The following is a description of a gene set: studied in species Homo sapiens Reactome Pathway: Defective B3GALT6 causes EDSP2 and SEMDJL1 The biosynthesis of dermatan sulfate/chondroitin sulfate and heparin/heparan sulfate glycosaminoglycans (GAGs) starts with the formation of a tetrasaccharide linker sequence attached to the core protein. Beta-1,3-galactosyltransferase 6 (B3GALT6) is one of the critical enzymes involved in the formation of this linker sequence. Defects in B3GALT6 causes Ehlers-Danlos syndrome progeroid type 2 (EDSP2; MIM:615349), a severe disorder resulting in a broad spectrum of skeletal, connective tissue and wound healing problems. Defects in B3GALT6 can also cause spondyloepimetaphyseal dysplasia with joint laxity type 1 (SEMDJL1; MIM:271640), characterised by spinal deformaty and lax joints, especially of the hands and respiratory compromise resulting in early death. part of: Diseases associated with glycosaminoglycan metabolism, and this is the list of marker genes: HSPG2, VCAN, B3GALT6, BGN (biglycan), SDC3, GPC2, DCN, GPC4, CSPG5, SDC2, GPC6, SDC4, GPC5, GPC3, AGRN, GPC1, BCAN, NCAN, CSPG4, SDC1